Given this list of marker genes SIX6, CRB1, ATAD2, MEST, AHI1, DAPL1, ALDH1A1, CDCA7, ZIC2, HMGB2, ZFP36L1, DEK, CDH11, PTTG1, RAX, TOP2A, SFRP2, SHISA2, CENPU, MIS18BP1, MCM3, TBX2, S1PR3, HES1, ID3, VIM, CCND1, COL2A1, TYMS, RAN, MCM4, GMNN, HMGN2, LGR4, FZD5, PCLAF, SNRPG, CCDC34, CENPK, ANP32E, PIMREG, HNRNPA1L3, GINS2, MCM2, ID2, SRSF2, SLF1, CDK1, ARRDC3, NASP, H4C3, ODC1, MEIS1, CHD7, TMSB15A, HMGN3, SCUBE3, SORCS1, CENPM, PCNA, CPAMD8, FOXN4, CKB, MCM5 (NCBI Gene Id 4174), CRYAA, C19orf48P, COL9A1, EML1, TOX, RAB31, AURKB, PLEKHA1, CCNB2, MAB21L1, UHRF1, MAD2L1, FIGN, CKS1B, HELLS, CRABP1, CLRN1, NAP1L1, LRP2 (LDL receptor related protein 2), MDK, SOX2, CENPF, ATOH7, SPP1, CKS2, PCDH7, HMGA1, UBE2T, ZWINT, H2AZ1, LMAN1, IFITM3, FGF19, PLPP3, SNRPB, SRSF7, LGR5, ID1, NUSAP1, MSI2, UBE2C (NCBI Gene Id 11065), VSX2, MCM7, here is a description of the gene set: species: Homo sapiens Retinal Progenitor Cells Human Gene Set: HU_FETAL_RETINA_RPC from publication Hu Y, Wang X, Hu B, Mao Y, Chen Y, Yan L, Yong J, Dong J, Wei Y, Wang W, Wen L, Qiao J, Tang F (PMID 31269016)